The following is a description of a gene set: Human Gene Set: HE_LIM_SUN_FETAL_LUNG_C0_MID_AIRWAY_SMC_1_CELL species: Homo sapiens Mid airway SMC 1 from publication He P, Lim K, Sun D, Pett JP, Jeng Q, Polanski K, Dong Z, Bolt L, Richardson L, Mamanova L, Dabrowska M, Wilbrey-Clark A, Madissoon E, Tuong ZK, Dann E, Suo C, Goh I, Yoshida M, Nikolić MZ, Janes SM, He X, Barker RA, Teichmann SA, Marioni JC, Meyer KB, Rawlins EL (PMID 36493756), and this is the list of marker genes: ENTPD1-AS1, ARHGAP6, HHIP, CEP120, ALKAL1, MTARC1, NGFR, CNN1, HTRA1, MYL4, C3orf70, ENTPD1, LRRN1, HIPK2, LMOD1, ACTG2, COL23A1, FHL2, DACH2, ZNF536, NPB, TYRP1, NAV2, ENC1, ADAMTSL2, ARL4A, KCNK3 (potassium two pore domain channel subfamily K member 3), ANO4, LIMS2, PLXNA4, WNT5A, KLHL4, LDLRAD4, ZEB1, WFDC1, FENDRR, ADAMTS6, MYH11, CDH6, ISM1, LTBP2, CHRDL1, C16orf89, HHIP-AS1, FBXL22, PCSK5, IRAG1, TSPAN2, KCNMB1, PMEPA1, PLPPR4, PDGFC, SEMA6D, MTCL1, TRAF5, IGF1, SSC5D, SEMA3C, EYA4, BCL11A, SPEG, KIF26B, RASL11B, FBXO32, RELB, EPCAM, SLC29A3, MYOCD, PLP1, RHCG, SLC16A3